The following is a description of a gene set: electronically inferred by orthology from the curated human pathway studied in species Mus musculus Reactome Pathway: MET activates RAP1 and RAC1 part of: MET promotes cell motility This event has been computationally inferred from an event that has been demonstrated in another species.<p>The inference is based on the homology mapping from PANTHER. Briefly, reactions for which all involved PhysicalEntities (in input, output and catalyst) have a mapped orthologue/paralogue (for complexes at least 75% of components must have a mapping) are inferred to the other species., and this is the list of marker genes: Grb2, Gab1 (growth factor receptor bound protein 2-associated protein 1), Hgf, Crk